Given this list of marker genes CASP8, FCGR2A, PHIP, DSG1, LRBA, DNAI2, SCNN1A, DPYSL5, CARMIL2, TP73, NELFA (negative elongation factor complex member A), LIG4, OAS1, ALG12, CD247, TTC7A, CTSC, WIPF1, CLCA4, CCDC22, GCLC, IL7R, UQCRH, RFXAP, HERC2, FOXP2, C1QB, POLE, HLA-DPB1, SMARCE1, HCK, CTNNBL1, CD8A, PLEC, FOXJ1, REEP1, SMARCC2, OCA2, COL4A5, IER3IP1, BTK, ELP1, LAMA2, GLB1, AICDA, TLL1, ZAP70, TSC1, MKRN3, TONSL (NCBI Gene Id 4796), BMP4, SCN2A, GAS2L2, PLCG2, SMARCA2, RAG2, PPP1R21, DNMT3B, SPI1, PWAR1, TPM2, PNKP, ARID1A, SMARCA4, TECPR2, LAMB2, BCR, GTF2IRD2, TCIRG1, LEP, AGR2, WAC, MYL9, SCN10A, MIR140, AP3B1, IRAK4, LTBP1, CYP4F22, ACP5, SNORD115-1, GLUL, MEGF10, DOCK11, GRM7, SNX10, CARD10, TRPS1, GTF2H5, H4C5, FLII, CXCR4, UNC119, ODAD2, ARX, SIAH1, TBX1, MESP2, ELN, PIK3CG, CBLB, PIK3CD, TBC1D24, ABCA12, INPPL1, STX1A, MPLKIP, UHRF1, ERCC2, MYO5A (NCBI Gene Id 4644, myosin VA), MYSM1, TNFRSF13B, EP300, SERPINH1, LAMTOR2, RPGR, UBE2A, SOX4, TINF2, ITGA7 (integrin subunit alpha 7), TRIM37, NFKBIA, RAC2, FUT8, ELANE, GNAO1, TCTN3, NRAS, AGRN, GAS8, CLXN, IKBKB, CTCF, RNF125, KCNN4, IL17RA, SLC19A1, MTHFD1, MDFIC, SMPD1 (sphingomyelin phosphodiesterase 1), RAB3GAP2, TYK2, GATA2, EHMT1, CCDC103, DOCK8, LMNB1, TCF3, TNNT2, ELF4, CARD11, HMOX1, MS4A1, GTF2I, ZBTB24, SLC6A14, BLM, STING1, SELENON, DNAH11, BLNK, GORAB, DYM, SLC26A9, RTEL1, GFI1, CCDC39, NGLY1, TSC2, SFTPC, TAP2, NSD2, MAGEL2, RNU4-2 (RNA, U4 small nuclear 2), RAC1, RASGRP1, PRKDC, ARID1B, SNRPN, TBL2, FOXN1, TBCD, NEUROD2, VPS35L, SATB1, ERCC3, KRAS, RAP1B, IKBKG, CCDC65, CRKL, STAT1, SLC39A7, SPINK5 (serine peptidase inhibitor Kazal type 5), LRRC8A, ASXL1, POLD3, SUCLG1, ARSB, PLOD1, AP3D1, PEPD, KCNJ6, ODAD3, DNAAF11, ARHGEF1, POGZ, B2M, CCDC40, CFTR, TGFB1, SHROOM4, CFAP221, TAPBP, TNFRSF1A, CD40LG, SLC11A1, ROR2, DDX59, DOCK2, TIMMDC1, PNP, CEACAM6, CHAMP1 (chromosome alignment maintaining phosphoprotein 1), EXTL3, PTEN, ASPRV1, FLI1, GNPTAB, RFXANK, TERC, ZNHIT3, PKHD1, IGLL1, MRAP, CDCA7, MYPN, LAT, FCHO1, MAPK1, TFRC, CD3E, LIMK1, LIG1, STIM1, HYDIN, AGA, WASHC5, EIF4H, TBK1, TNFSF11, AASS (aminoadipate-semialdehyde synthase), NDUFC2, TPM3, PRKCD, DNAJB13, ARID2, MGP, WDR35, SIK1, NFKB1, SIM1, IRF8, FBXO11, KIAA0586, IVNS1ABP, KDM6A, TBC1D23, MIF, HPS6, GEMIN4, CD3D, IGHG2, TAOK1, TNFRSF13C, PWRN1, ALDH18A1, NME5, MDM4, CACNA1B, ZNF341, CPLX1, HYOU1, ODAD1, GAA, CFI, JAK3, SLC1A4, UFC1, IDUA, GRIA1, LYST, NBN, DPP9, ALB, SPEF2, GBA1, PKP1, ODAD4, ARPC5, NFKB2, CCBE1, TGM1, FLNC, OFD1, PEX5, IDH1, DNAI1, PSAP, SLC37A4, LIPN, TET2, CTC1, STK36, TNNI3, SLC18A3, FMO3, CEBPE, POLR3A, DYNC2I2, SOCS1, RUNX2, NEPRO, KMT2D, TRIP11, SH3KBP1, PAK2, COL11A2 (collagen type XI alpha 2 chain), TOM1, CFAP410, NOTCH2, ITGA3, RNF168, SCN1B, MASP2, CYBB, KCNA1, SMARCB1, MCIDAS, NDN, MYH3, SAMD9L, RYR1, C3, SERPINA1, MED25, ACBD6, NIPAL4, TBCE, POLD1, BRWD1, TRAIP, DNAJC30, DNAH9, COL4A6, PIGP, MAGT1, NFE2L2, GNS, HLA-DRB1, COL6A2, FOXP3, CSPP1, SLC25A22, NEK10, ORC6 (NCBI Gene Id 23594, origin recognition complex subunit 6), CLIP2 (CAP-Gly domain containing linker protein 2), IFT122, CD27, GRIN1, TAP1, IDS, DNAAF1, LEPR, SCNN1B, VARS1, KAT6A, SRP19 (signal recognition particle 19), TASP1, DNAH1, IL2RG, COLQ, TRAF3IP2 (NCBI Gene Id 25997), MALT1, XIAP, ALPL, VPS37D, TRAC, CLCN7, SEC61A1, ALOXE3, TBX6, WRAP53, SH2D1A, STAT6, DNAAF5, COL13A1, TCEAL1, SLC41A1, SOX11, SPTBN4, IL17F, TAFAZZIN, COG4, CR2, ATP6V0A2, FOXP1, NKX2-1, SCN11A, NCF2, DRC1, PGM3, ADNP, ICOSLG, TMCO1, G6PC3, RAI1, CEACAM3, WDR1, USP9X, UNG, KRT5, GTF2E2, DEAF1, GTF2IRD1, ZNF668, IL17RC, RAG1, SULT2B1, ITCH, HELLS, CD55, SLC26A2, CD4, ZNFX1, MBTPS2, ADA2 (adenosine deaminase 2), LETM1, ZMYND10, PARN, COG6, IFIH1 (NCBI Gene Id 64135), IL10RB (NCBI Gene Id 3588), FCGR3A, DNAH5, UGP2, HFE, SASH3, MTM1, TK2, CFAP74 (cilia and flagella associated protein 74), CLEC7A, RFT1, WAS, ECM1, CCNO, SP110 (NCBI Gene Id 3436), IGBP1, VPS33A, SDR9C7, ADAMTS3, PCGF2, FLNA, HLA-B, CASK, CD79A, H4C3, CLPB, STAT3, MANBA, MCM4, KATNIP, SPAG1, IL21R, OCRL, NFASC, CD79B, COL6A1, CHAT, PYROXD1, CYBA, PSMD12, DEPDC5, EPG5, PRTN3, SCNN1G, TRIM8, CHRM3, ACTA1, RFC2, ARSL, POLA1, LCK, GMNN, DCTN4 (dynactin subunit 4), FKBP6, SLC52A3, IL2RA, CFAP298, POLR2A (RNA polymerase II subunit A), BUD23, IGKC, CARS1, NAGLU (NCBI Gene Id 4669), RSPH4A, TTC12, SCN9A, EGFR, BIRC3, CTBP1, NPM1, DIP2B, ALMS1, PIGG, TRIP4, FBXO28, ARPC1B, SLC29A3, CYBC1, COL5A2, B3GALT6, KIF20A, GALNS, GSTM3, KDM5C, DNAAF4, SMARCD2, FCN3, CTLA4, TERT, STXBP2, DNAL1, HGSNAT, SMARCD1, VPS51, RSPH1, GUSB, EFEMP2, C4B, SYT2, UBA2, TNFRSF9, SGSH, NHLRC2, ERCC6, P4HA2, ATM, DDR2, IL21, DNAAF6, NUP214, METTL27, TPP2, ZBTB7A, DKC1, MAP3K14, TMEM270, ASAH1, FCSK, DNAAF2, PCNT, BCL10, MSN, MECP2, CD19, MYL2, P4HTM, DMXL2, ADA (adenosine deaminase), STK4, PLVAP (plasmalemma vesicle associated protein), SLC35C1, TNFSF12, PRPS1, NCF1, USP26 (NCBI Gene Id 83844), SNORD116-1, VAMP1, IRF1 (interferon regulatory factor 1), TNFRSF11A, DPF2, NOP10, IRF2BP2, CAVIN1, TARS1, RNU4ATAC, IL6R, IFT56, NCF4, PURA, NME8, RNF113A, PLG, JAGN1, CDKL5, SLC5A7, ERF, NAE1 (NCBI Gene Id 8883), SLC25A1, USB1, SLC46A1, AK2, NPAP1, IKZF1, HLA-DPA1, AARS1, GLI3, SMN1, PTPN22, IGHM, LRRC56, NFIX, ALOX12B, DAW1, RFX5, RELB, MGAT2, CD81, RSPH9, CIITA, CD3G (NCBI Gene Id 917), FBXW7, CORO1A, BAZ1B, DZIP1L, KAT6B, NECTIN1, LTBP4, DLL3, IQSEC2, TYMS, PIK3R1, RFX7, SLC32A1, PIGQ, PLP1, ICOS, FUCA1, FAT4, CFAP300, SNAP25, SETBP1, MYO9A, EDARADD, HACD1, COL5A1, KANSL1, IL6ST (NCBI Gene Id 3572), TMEM94, CREBBP, SREBF1, PSMB8, PET117, KPTN, EXOSC9, WDR19, DNAAF3, SDCCAG8, DPM2, NHP2, BACH2, EDNRA, STX3, GFM2, MAP3K20, IL2RB, RSPH3, SLC4A10, DCLRE1C, NXN, SOX9, RNH1, UMPS, FBLN5, IFT140, SLC9A3, RIPK1, here is a description of the gene set: Recurrent respiratory infections An increased susceptibility to respiratory infections as manifested by a history of recurrent respiratory infections. Human Gene Set: HP_RECURRENT_RESPIRATORY_INFECTIONS species: Homo sapiens